The following is a description of a gene set: Protruding tongue species: Homo sapiens Tongue extending beyond the alveolar ridges or teeth at rest. Human Gene Set: HP_PROTRUDING_TONGUE, and this is the list of marker genes: RNU4-2, TAF1, SNRPN, CSNK2B, NRXN1, GRIK2, PI4KA, NEU1, OCA2, DNM1, RALGAPA1, ADGRG1, VPS13A (NCBI Gene Id 23230), FBXO28, KIF7, GLB1, SRPX2, CNTNAP2, UHRF1, HMBS, NFIX, PIGB, DNMT3B, UBE3A, SLC25A24, LAMA2, COG7, INPP5E, ZFX, CSNK2A1, ATRX, DHX30, SET, TRIP11, PEX1, LMNB1, PTH1R, EHMT1, MGAT2, ZBTB24, FAM20C, CLIC2, FTO, HELLS, CCDC22, CDCA7, ZNF699, SLC35C1